Given this list of marker genes SIRT1, POLR2F, CDR2L, SEC11A, PTPN18, SEPTIN10, SCP2, SCN10A, TMEM245, MRPS14, GALK2, OGFOD2, ARF1, SIGLEC1, LDB1, SELENOK, NAB1, ADAMTS1, RIOX2, POLR2J, MRPS7, ASAH1, RPA3, DNAJC9, BMP2K, RMND1 (NCBI Gene Id 55005), MATR3, ANLN, RER1, CISH, PROS1, CWC15, PPIH, SEPTIN4, ABRACL, PGAM1, AMOT, FBXO38, RUNX1T1, PKHD1, ANKRD13A, DSTN, HTR2C, FOLR2, NCOA2, PPIE, S100PBP, RNF181, GZMM, CDCA5, MTARC2, MPHOSPH10, KMT2E, MRPS25, NRG3, CLCNKB, CD70, CNP, GNPNAT1, SEMA3F, MXI1, MTHFR, ARAP3 (ArfGAP with RhoGAP domain, ankyrin repeat and PH domain 3), SEPHS2, PIP4K2A, ARL2, BRD7, CYB5B, MFSD14A, MAST2, RBM26, ECPAS, ADAMDEC1, SEPTIN7, DNAJB1, SERPINE2, HSD17B11, NUDT5, TDRP, CAMK2D, B3GAT3, ATF2, MOGAT2, ASF1B, DNAJA1, CRP, NFU1, LITAF, DEK, COPE, PPP6C, GTF2H4, RNASE3, KTN1, MRPL9 (NCBI Gene Id 65005), CSTF2, CLDN5, RIPOR2, NSMCE1, CDON, KIF3B, IMPA1, COASY, S1PR1, NT5DC3, MBD4, MSRB1, IREB2, DCUN1D5, DPT, ROCK2, MRPS21, YJU2B, SAYSD1, CD3E (NCBI Gene Id 916), BTF3L4, ARPC5L, ACRV1, PDCD2, CCKAR, LRRC58, INTS8, MRPL13, CBR1, RERE, CYBB, ENO1, LEPROT, GJB2, SAP30L, ATP5PF, H1-4, HMGB2, AKAP8, IFIT2, GABPA, IKBKB, GLMP, NUTF2, SHF, SLC25A28, MPHOSPH9, CTSC, FRAT1, PLG, SERTAD1, MORC4, RACK1, MKNK1, FKBP1A, NUSAP1, KPNA6, KIF3C, GSTT2, MC5R (NCBI Gene Id 4161), GCH1, NFE2, MIX23, EMP3, SLU7, RP9, HOXC5, COQ9, FMC1, GNB1, MRPL27, MAT2B, ACE, FIP1L1, BARX1, GRPEL2, PMPCB, MAPKAPK5, ROCK1, ATP6V1B2, IQGAP2, SLMAP, SAA1, DDX52, RBBP4, IVNS1ABP, SGPP1, PTPN2, PGM1, PCBD2, EGLN2, LUC7L3, LACTB2, GPR37, HNRNPC, NOP58, FLT3, SLC25A4, LY75, MEOX1, C9orf78, RAB4A, PRMT3, COPA, B4GALNT1, here is a description of the gene set: Differentiation of naive CD8 T cells into cytotoxic effector cells requires three distinct signals- antigen (signal 1), costimulation -B7-1 (signal 2) and cytokine, either interleukin-12 or interferon-a/b (signal 3). Interaction of naive CD8 T cells with antigen and B7-1 programs cell division and proliferation whereas the presence of cytokines- IL-12 or IFNa/b promote survival, differentiation and memory establishment. In the absence of signal 3, the cells interacting with antigen/B7-1 undergo tolerance induction. The objective of this study was to elucidate the mechanisms how the provision of signal 3 promotes differentiation and averts tolerance induction in CD8 T cells. Trichostatin A is a pharmacological agent that inhibits histone deacetylase activity, hence regulating chromatin structure and gene expression and differentiation in many cell types. Gene signature profiles of IL-12, IFNa/b and trichostatin A stimulated cells were compared to elucidate the molecular mechanisms of gene regulation. Oligonucleotide microarray analysis is carried out to determine the extent and molecular nature of the CD8 T cell differentiation program induced by IL-12 or IFNa/b in concert with antigen and B7-1 signal. studied in species Homo sapiens from publication Agarwal P, Raghavan A, Nandiwada SL, Curtsinger JM, Bohjanen PR, Mueller DL, Mescher MF (PMID 19592655) Genes up-regulated in comparison of unstimulated CD8 T cells at 24 h versus CD8 T cells at 24 h after stimulation with IL12. Human Gene Set: GSE15930_STIM_VS_STIM_AND_IL12_24H_CD8_T_CELL_UP